The following is a description of a gene set: studied in species Homo sapiens Human Gene Set: MIR491_5P from publication Chen Y, Wang X (PMID 31504780) Genes predicted to be targets of miRBase v22 microRNA hsa-miR-491-5p in miRDB v6.0 with MirTarget v4 prediction scores > 80 (high confidence targets)., and this is the list of marker genes: TDP2, ZNF644, TNNI3K, MIER3, FHIT, TMEM69, PARVA, FZR1, FOXP4, TFAP2B, AGPAT1, SCYL3, UTP25, RNF2, DNAJB5, SHOC2, AMD1, PDK4, LRFN1, KCNA6, BARHL2, ELN, GALNT17, FGD1, FPGT-TNNI3K, FBXO41, GANC, HSPB6, MPL, INO80D, KRTAP2-3, ZNF609, KCNE1, KSR2 (NCBI Gene Id 341537), TMEM43, IGF2, MDK, TMEM35A, C2CD2L, ABCD4, ASB13, MEX3A, OPTC, CSRNP2, DNAJA2 (DnaJ heat shock protein family (Hsp40) member A2), FXN, MOCS1, SAMD4B, PIP4P1, KAT7, ERF, HCFC1R1, ARHGAP33, BCL6B, MYT1L, NIPAL2, GRAMD1B, PDXK, POGK, CD177, ZFP36L1, GATAD2B, MSN, APH1A, TAF5L, SHISA6, NCOA7, CHRNB2, TSKU, SYNGAP1, PYGM, DOK4, GALNT2, ILRUN, RFWD3, TXNL4B, B4GALT5, EXOC8, TMEM218, ZNF519, CLXN, TMED7-TICAM2 (NCBI Gene Id 100302736), KIF21B, TICAM2, GIPC1, MRPS35, ELAVL4, CSRP1, OTP, SEMA6A, ZNF703, ATP5MC3, STRN, TP53, VSX2, KCNT2, CPNE7, LYPLA2, SEC24A, MTSS1, OGG1, CPNE5, GIT1 (GIT ArfGAP 1), TERT, FAM218A, PTK7, TAF10